Given this list of marker genes SLC2A2, AKT2, PHKG2, SDHA, PGM1, SLC37A4, SHARPIN, HNF4A, FOCAD, PYGL, FARS2, PHKB, here is a description of the gene set: Abnormal hepatic glycogen storage Human Gene Set: HP_ABNORMAL_HEPATIC_GLYCOGEN_STORAGE species: Homo sapiens Change in normal glycogen storage content.